The following is a description of a gene set: A subjective feeling of tiredness characterized by a lack of energy and motivation. Fatigue species: Homo sapiens Human Gene Set: HP_FATIGUE, and this is the list of marker genes: TBX20, BCL6, SLC25A11, TERC, AIP, COL9A2, SDHB, IMPDH2, PLEC, CLCN7, MEFV, GET3, PRPH, SMAD3, SLC4A1, COQ2, CHMP2B, ANKRD1, GATA4, PON3, IKZF1, PHOX2B, MLH1, MET, TCAP, PML, SCN3B, MDH2, ACTC1, KIAA0319L, PLN, STAT5B, ACTA1, ZBTB16, POU1F1, FTL, BCL2, AEBP1, CARMIL2, ZMYM3, KIF1B, DNAJC6, GPR101, MC2R, KPNA3, THRB, SFTPA1, NLRC4, NR4A2 (NCBI Gene Id 4929), NF1, TLL1, IRF5, HAND2, EPAS1, PALB2, IL12A, GRM1, AP2S1, SELENON, NLRP3, ALDH4A1, FCGR2B, RARA, DSP, PARN, CFH (NCBI Gene Id 3076), POMGNT1, TAF15, DAO, SLC12A3, ABL1 (ABL proto-oncogene 1, non-receptor tyrosine kinase), LDB3, IL12A-AS1, ERCC4, NUP155, SDHC, FKTN, DSG2, PSEN1, LRRC8A, DLST, KIF23, AP1S3, TSHR, OPTN, PIK3R1, PHKG1, SERPINA6, SDHAF2, HLA-B, WIPF1, ATP13A2, POU2AF1, HLA-DPA1, ETS1, SLC40A1, HFE, NPM1, PIK3CG, GATAD1, PSTPIP1, TBL1XR1, TREX1, CDH23, SMAD4, CD79A, DCTN1 (NCBI Gene Id 82109), TXNRD2 (thioredoxin reductase 2), RBM20, RYR1, TBX19, RIN2, SLC34A2 (NCBI Gene Id 153010), ABCA3, CTLA4, TET2, TNFSF15, GLT8D1, TNFAIP3, ATP13A3, IRF4, NEFH, C4A, PHKA1, IL23R, CD46, PSAP, ASXL1, GLI2, RRM2B, MYCN, POLR3GL, FIG4, COL5A1, PDCD1, PGM1, ACADM, DDB2, CBL, TP53, PNPLA8, MRAP, PTPN3, UBAC2, STAT6, COL5A2, TLR4, PHKB, TNNI3, LMOD2, CCND1, HEPHL1, PIK3CA, MYL2, MUTYH, BCOR, CAP2 (NCBI Gene Id 10486), COL1A2, SMAD2, UNC93B1, CDC73, IGKC, TNFSF4, ERCC5, CIITA, EPCAM, IL18BP, PREPL, SLC26A4, CR2, PRKAR1A, VHL, JAZF1, GATA6 (GATA binding protein 6), NKX2-6, UBA1, RUNX1, BMPR1A (NCBI Gene Id 8035), CDKN2A, SIN3A, DES, MSH6, SLC22A4, PAX8, MYBPC3, HNF4A, TARDBP, TNNC1, CCR1, HACE1, UBQLN2, BRCA1, RAPSN, MST1, SOD1, TMPO, BRCA2, ABCC9, VCL, DNASE1, POLG2, RTEL1, PRTN3, MYT1L, SFTPC, KCNJ3, PHIP, LIN28B, EPOR, EPB41, BTK, ASCC3, ATXN2, TNNT2, KL, MAX, SI, IL12B, LHX3, PIEZO1, MAP3K20, TBK1, GCK, TPM2, UBE2L3, PHKA2, EIF2AK4, BIRC3, C1QBP, MMEL1, CTNNB1, HBA1, C4B, MLX, OTX2, RET, TFR2, PHEX (phosphate regulating endopeptidase X-linked), TERT, CHEK2, GLE1, STAR, TSC2, RACGAP1, NR0B1, SGCD, SOX3, PALLD, FIP1L1, PPCS, ABCC2, IL36RN, ARNT2, HNRNPA1, VAPB, GJA5, FAM13A, MDM4, SEMA4A, LYN, NPPA (NCBI Gene Id 90230), POLD1, HESX1, MORC2, SQSTM1, GCH1, IRAK1, MATR3, LBR, HLA-DPB1, CHCHD10, KCNJ5, ATM, ERCC3, ITGAM, ATRX, STAT1, TMEM127 (transmembrane protein 127), NKX2-1 (NK2 homeobox 1), SH2B3, ANG, TK2, LMNA, SCN1B, BTNL2, SDHA, TNIP1 (TNFAIP3 interacting protein 1), KRAS, TMEM126B, UNC13A, SCNN1G, SEMA4D, ROS1, PON2, RHAG, IRF2BP2, FCGR3B, SRSF2, IL12RB1, KCNJ2, TRAF3, TICAM1, TAFAZZIN, RAF1, KLRC4, TNXB, PODXL, NFKB2, FGFR1, PON1 (paraoxonase 1, NCBI Gene Id 5444), BCR, DNM1L, IL10, TPM3, TREM2, FOXP1, WAS (NCBI Gene Id 7454), GIMAP5, HLA-DRB1, PIGT, SLC18A2, CITED2, YY1, UNC45B, TRIO (NCBI Gene Id 7204), CD244, AGK, SPTBN1, MYL4, PLEKHM1, MYH6, IFNGR1, PHKG2, BLNK (NCBI Gene Id 29760), TCF3, ATP7A, IVNS1ABP, SLC3A1, CCNF, SPTA1, BMP6, MYPN, PPARGC1A (PPARG coactivator 1 alpha), MYH7, MEN1, TLR7, LRIF1, LAMA4, MMADHC, SLC2A10, KCNE2, SFTPA2, PTPN22, PDGFRA, SPTB, PMS1, PROKR2, TPM1, SCNN1A, ABCD1, SLC39A7, SCN5A, GBA1, P4HA2, FUS, SCN4A, HELLPAR, BCL10, IGLL1, ALB, TSHB, IL21, CFI, CSRP3 (NCBI Gene Id 8048), MALT1, LMO1, SYNJ1, ERAP1, SLC25A26, RABL3, SOX2, TCF4 (NCBI Gene Id 6925), ERCC2, MECP2, CNBP (CCHC-type zinc finger nucleic acid binding protein), DPP9, NFKBIL1 (NFKB inhibitor like 1), FHL2, CRYAB, PITX2, TTN, GPR35, FOXA2, IGHM, HBA2, HACD1, INSR, CAV3, GYPC, MT-TK, BAG5, NNT, RPL3L, CPT1A (NCBI Gene Id 1374), KIT, OPA1, BANK1, VEZF1, MSH2, TGFBR2, ELANE, HAVCR2, SCN4B, ATP11A, VCP, BLK, CALR, STN1, FAS, PXK, NAXE, SCNN1B, PFN1, XPA, TAF1A, GFAP, PRDM16, NEXN, FH, COL1A1, HMGCL, KCNN4 (NCBI Gene Id 3783), KCNQ1, STEAP3, ITGA7, JAK2, CFAP410, FGF23 (NCBI Gene Id 8074), NKX2-5, NUMA1, JPH2, RPS20, ARMC5, ACTN2, STAT4 (signal transducer and activator of transcription 4), TNPO3, POLE, TSC1, SLC25A4, ALAS2, NABP1, DMD, ERBB4, FOXE1, DOLK, PROP1, DBH, MYD88, GATA2, SCN2B, PYGM, PMS2, DNMT3A, IGHG1, ANXA11, TGFBR1, MUC5B, KCNA5, DYSF, POLG, LHX4, PSEN2, NAA80, TRHR, ALK, SPP1 (NCBI Gene Id 6696), NR3C1, SLC18A3, GLA, TLR3, IGHG2, SPIB, XPC (XPC complex subunit, DNA damage recognition and repair factor), NAB2, TWNK, PABPN1, NEK1, KCNE1, NAGS, MPL, PPP2R5D, CD79B, GATA5, BAG3, SPI1, STAT3, SDHD